The following is a description of a gene set: Human Gene Set: GOBP_NEGATIVE_REGULATION_OF_ACTIN_FILAMENT_DEPOLYMERIZATION species: Homo sapiens Any process that stops, prevents, or reduces the frequency, rate or extent of actin depolymerization., and this is the list of marker genes: TRIOBP, CARMIL2, SPTBN5, CAPZA1, TMOD1, CAPZA2, GSN, CAPZA3, MTPN, EPS8, WASHC2C, PLEKHH2 (NCBI Gene Id 130271), VILL, ADD2, TWF1, RDX, CAPZB, CAPG (capping actin protein, gelsolin like), CARMIL1 (NCBI Gene Id 55604), SPTBN4, LMOD3, SPTAN1, LMOD2, CRACD, AVIL, SWAP70, SPTBN2, LIMA1, SPECC1L, TWF2, ADD3, DMTN, SVIL, SPTBN1, LMOD1, TMOD3, TMOD4, ASB2, SPTB, TMOD2, VIL1, FLII, SCIN, PIK3CA, ADD1, SPTA1, CFL1